The following is a description of a gene set: studied in species Homo sapiens Human Gene Set: GOBP_REGULATION_OF_VITAMIN_METABOLIC_PROCESS Any process that modulates the frequency, rate or extent of the chemical reactions and pathways involving a vitamin, one of a number of unrelated organic substances that occur in many foods in small amounts and that are necessary in trace amounts for the normal metabolic functioning of the body., and this is the list of marker genes: SNAI1, CD320, AKR1C3, PRMT3, TNF, GFI1, IFNG, RDH10, CLYBL, NFKB1, SNAI2